The following is a description of a gene set: studied in species Homo sapiens Human Gene Set: GOCC_HIPPOCAMPAL_MOSSY_FIBER An axon of a hippocampal granule cell, including dentate gyrus granule cell and CA3 granule cell, characterized by expansions (mossy fiber expansions) giving the fibers a mossy appearance. These unmyelinated axons were first described by Ramon y Cajal., and this is the list of marker genes: MAPK8IP1, MICAL1, TNN, SLC30A3, MAP1B, SLC4A8